Given this list of marker genes Serpina1d, Serpina1a, Serpina1e, Mt1, Serpina1b, Serpina1c, here is a description of the gene set: Any process that results in a change in state or activity of a cell or an organism (in terms of movement, secretion, enzyme production, gene expression, etc.) as a result of a chromate stimulus. Mouse Gene Set: GOBP_RESPONSE_TO_CHROMATE species: Mus musculus